Given this list of marker genes NRL, CFH, TEAD1, EFEMP1, CFI, here is a description of the gene set: Chorioretinal atrophy concentrated around the optic papilla (i.e., the optic nerve head). Human Gene Set: HP_PERIPAPILLARY_CHORIORETINAL_ATROPHY studied in species Homo sapiens Peripapillary chorioretinal atrophy